Given this list of marker genes Chrna7, Nfe2l3, Znrf2, Plxna1 (plexin A1), Cdh10, Acvr2a, Nrxn1, Cdh12, Bmp3, Wnt7b, Ogfrl1, here is a description of the gene set: from publication Bedogni F, Hevner RF (PMID 34321999) Mouse Gene Set: HEVNER_SUBPLATE_PROJECTION_NEURONS species: Mus musculus Genes selectively expressed by postmitotic projection neurons in the subplate of embryonic day 14.5 mouse cortex.